Given this list of marker genes NCBP1, FAH, POLR3K, AIMP2, SPATS2L, CLIC2, TPX2, ACOT7, CCNB1, KIF4A, CKS1B, HMGB3, ATOX1 (antioxidant 1 copper chaperone), CENPA, CYC1, MCM7, NIT2, AARS1, FEN1 (NCBI Gene Id 5882), TRAP1, MCM2, STIP1, IL2RA, DAPK1, ALAS1, ALDH2, IL1R1, LRRC42, GINS2 (NCBI Gene Id 51659), ETNK1, SLC6A12, TMEM106C, RFC4, WDR76, ME2, IDH1, RIDA, RBM4B, IL1R2, CTPS1, WARS1, GINS3 (NCBI Gene Id 92916), TRIP13, TNS3, H2BC9, RNASEH2A, FANCI, TYMP, MRPL35, SRPK1, CHEK1, SPAG5, CCT3, MLYCD, TUBB6, BCL2L11, ARFIP1, PGAM1, VDR, DLGAP5, TMPO, LAMP3, IL13RA1, ANPEP, MCUR1, PCLAF, MRPL11, TALDO1, RMI1, ACTG1, SFT2D2, LMNB2, DHFR, RACGAP1, HJURP (Holliday junction recognition protein), CSTF2, MYL6B, EBNA1BP2, NME1, HMMR, MRPL12, DTL, RFC5, GSTO1, HILPDA, NCAPH, RAD51C, GOT2, TUBA1B, RBX1, GART, PPM1G, CDC6, GADD45GIP1, ASPM, CEP55, HADH, CKAP5, TUBB, CENPF, PCK2, HCP5, DPP3, ESPL1, KIF2C, KIF11, SPDL1, CCNB2, GMPPB (GDP-mannose pyrophosphorylase B), POLA1, JPT2, PHB1, MRPL18, FANCG, UCK2, ADSL, CKS2, SHMT1, MRPS14, PSMB6, NUP133, IRF4, PSMB5, GAPDH, CDK2AP1, KIF20A (kinesin family member 20A), RPA3, TK1, TUBG1, NCAPG2, MPV17, KIF15, LXN, ZNF189, PHLDA1, UBE2A, POLE2, PRIM1, TYMS, MELK, NUDT1, BUB1B, TUBA1C, CENPU, HSD17B10, DCTPP1, SNUPN (NCBI Gene Id 10073), CDK4, TXNL1, SUCLG1, SLC39A14, IMPDH2, UNG, BLM, MCM10, TOP2A (NCBI Gene Id 7153), NCAPG, TP53BP1, CD2BP2, AURKB, CREG1, TOR1A, PSMG1, NELFE, KPNA2, EIF2B4, CENPM, SPRED2, FH, EMC9, TBC1D8, SLCO4A1, JPT1, PAICS, RRM2, PSMD2, RAD51AP1 (RAD51 associated protein 1), KEAP1, IARS1, MCM4, NUDC, GCLM, BDH1, STMN1, SLC43A3, CSTA, SEPHS2, RFC3, RANBP1, IER3, SMC2, MRPL15, RAD51 (RAD51 recombinase), NUP37, POLR2H, ZWINT, CDC25A, AURKA, MTHFD1, MSRB2, here is a description of the gene set: Human Gene Set: GSE36476_CTRL_VS_TSST_ACT_40H_MEMORY_CD4_TCELL_OLD_DN Genes down-regulated in comparison of untreated CD4 memory T cells from old donors versus those treated with TSST at 40 h. from publication Yu M, Li G, Lee WW, Yuan M, Cui D, Weyand CM, Goronzy JJ (PMID 22434910) species: Homo sapiens With increasing age, the ability of the immune system to protect against recurring infections or to control chronic infections erodes. The objective of the current study was to identify gene expression signatures in elderly CD4 T cell responses